Given this list of marker genes LRRC23, MARK4, HAP1, WDR11, CFAP119, TESK1, CFAP74, AHI1, MCRS1, CEP250, PRICKLE1 (prickle planar cell polarity protein 1), CEP78, CFAP263, CFAP57, MICALL1, CFAP97D1, TAPT1, SSNA1, CC2D2B, PPP1R35, PKHD1, DNALI1, KLC3, CYLD, TMEM237, B3GLCT, GSN, SEPTIN7 (septin 7), CCDC65, TBC1D2B, E2F4, DYNC2I1, TMEM80, CEP19 (NCBI Gene Id 84984), CPLANE1, DZIP1L, PLA2G3, RFX4, MNS1, KIF27, CEP89, POC1A, WDR44, CFAP221, CFAP410 (cilia and flagella associated protein 410), RSPH4A, CILK1 (ciliogenesis associated kinase 1), ONECUT1, CDC14C, LRRC61, FAM161A, GDI2, ODF2L, CFAP70, IFT52, CCNO, GMNC, RILPL1, TMEM138, FLNA, CFAP73, B9D1 (B9 domain containing 1), FNBP1L, CFAP20, CBY1, TEKT4, TBC1D3, WDR90, PCM1, HYLS1, ATXN10, RFX3, MAK, FBXW8, RABL2B, NEURL1, NEDD9, GFY, PLK4, CEP120, TBC1D7, TBC1D30 (NCBI Gene Id 23329), CCDC38, CFAP100 (NCBI Gene Id 348807, cilia and flagella associated protein 100), BBOF1, CCDC88A, RABEP2, CFAP44, DNAI3, DZIP1, TBC1D16, FSIP2, C2CD3, TRIM32 (NCBI Gene Id 3971), RP1L1, TBC1D21, SPACA9, CFAP46, ROPN1, FBF1, ARL3, CWH43, LUZP1 (NCBI Gene Id 7798), TCTN1, HOATZ, MAPRE1, EHD1, CIMAP3, CENPJ, CCDC13, NME8, PIERCE2, SGSM3, INTU (NCBI Gene Id 27152), SPEF2, DNAAF1, TCTN2, TBC1D15, TTLL8, KCNQ1, CEP20, WDR35, RP2, CCDC63, DYNLT2B, IFT56, DRC1, FOXJ1, CCDC40, CCDC159, DUSP23, SPEF1, ACTR3, PIERCE1, IFT88, LRRC46, IQUB, SPAG6, DNAI1, DNAH7, ADAMTS16, RAB3IP, RFX2, TBC1D14, DNAAF3, LIMK2, TBC1D10B, DNAH17, MAP4, BBS2, KIFAP3, TMEM231, BBS10, ATG5, AKT1, GBF1, KIF24, BBS1, IFT70B, DNHD1, ATP6V1D, DISC1, ATAT1, ALPK1, BBS5, RAB8A, CEP131, ODF2, DCTN1, ABLIM3, DYNLL1, FUZ, IFT43, BBS7, ROPN1B, KIF19, IFT27, EXOC5, CCDC88C, MARCHF7 (NCBI Gene Id 64844), UNC119B, DAW1, CFAP54, CEP97, STK36, LCA5, ATMIN, ARF4, TBC1D20, CFAP298 (cilia and flagella associated protein 298), EHD2, CFAP61, CEP70, LIMA1, CEP164, SCLT1, DYNC2I2, NUDCD3, JHY, POC1B, ELMOD3, CLXN, IFT70A, RSPH9, SAXO1, ENTR1 (NCBI Gene Id 10807), CFAP47 (cilia and flagella associated protein 47), NPHP3, CDKL5, ASAP1, RAB23, SPAG16, FHDC1, TTC29, DNAH1, EHD3, IFT172, YIF1B, ONECUT2, RSPH1, CFAP53, UBE2B, WDPCP, RO60, ZMYND12, DRC7, CCDC39, TPGS1, PFN4, WWTR1, ENKD1, CPLANE2, CFAP126, EVI5L, SSX2IP, PCNT, IFT57, CEP162, IFT25, TTC21B, MKS1, RILP, TBC1D10C, PARVA, CCDC15, CC2D2A, MACIR, KIF3B, TUB, DNMBP, TEKT3, CIBAR2, NEK1 (NCBI Gene Id 51037), CCDC103, DNAAF6, IFT20, DNAI2, CCDC42, KCNJ10, TBC1D31, CDC14A, ABCC4, WRAP73, CCP110, IFT81, SPAG1, TBC1D24, FAM149B1, TEKT1, TBC1D22B, CFAP91, RAB1A, TBC1D1, KIAA0753, CCDC57, BBS12, DNAH5, CDK10, GAS8, IFT140, DNAAF4, RTTN, AURKA, ACTR2, GORAB, TCHP, DYNC2LI1, ARL13B, LCA5L, DMD, FBXO24, KIAA0586, TCTN3, CFAP65, CFAP161, CEP290, TMEM67, OCRL, TBC1D17, DNAJB13, KCTD17, USP6NL, RAB11A, PIBF1, TTC12, GSK3B, FAM161B, NME5, TXNDC15, RPGRIP1L, MEIG1, TTLL1, TTC21A, DNAH2, USP9X, ARMC2, CFAP184, TBC1D32, LPAR1, SYNE2 (spectrin repeat containing nuclear envelope protein 2), IFT22, B9D2, ODAD1, RP1, SEPTIN9, TTC17, EHD4, IQCB1, TMEM216 (transmembrane protein 216), CFAP206, CCDC32, ERICH3, DNAAF10, DNAI4, TMEM107, IFT74, CSNK1D, TBC1D19 (NCBI Gene Id 55296), RAB11FIP3, ODAD2, PKD2, HTT, ZMYND10, CEP135, RAB34, TTLL3, RILPL2, ARL6, VANGL2, ARHGAP35, CNTROB, BLOC1S6 (NCBI Gene Id 26258), IFT80, PTPN23, GALNT11, BBS4, CELSR2, TTC8, NOTO, DNAAF11, CROCC, CFAP58, DTNBP1, CEP350 (centrosomal protein 350), IQCG, ARL13A, MAPK15, TBC1D13, DCX, IFT46, CATIP, CFAP43, CIBAR1, YAP1, CEP83, OFD1, TBC1D5, DCDC2, SPAG17, TMEM17, RABGAP1, TBC1D9B, NDUFAF2, BBIP1, RRP7A, TRAF3IP1, TBC1D8, CFAP157, CFAP69, GK2, WDR19, TOGARAM1, TSGA10IP, TBC1D22A (NCBI Gene Id 25771), TEKT5, ODAD4, CDC14B, HYDIN, INPP5E, CEP41, BBS9, DYNC2H1, NME7, ELMOD1, CEP126, DNAL1, SDCCAG8, DNAAF2, TTC39C, UBXN10, CDKL1, ARMC9, CLUAP1, NECTIN2, CEP128, TTLL5, SEPTIN2, KIF3A, AVIL, NHERF1, RPGRIP1, KCNF1, EVI5, TTBK2, DNAAF8, CCDC146, LAMA5, SNX10, ARMC12, MPHOSPH9, HDAC6, ATG3, SNAP29, NOTCH1, SPATA6, RAB8B, MKKS, ABLIM1, AKAP4, IFT122, TBC1D10A (TBC1 domain family member 10A), RSPH6A, ODAD3, PDCL2, ATP6V0D1, TEKT2, RAB17, VDAC3, RPGR, TBC1D2, CCDC28B, PTPDC1, MCIDAS, DNAH8, DNAAF5, TRAPPC14, CLCN4, LRGUK, CCDC66 (NCBI Gene Id 285331), here is a description of the gene set: Human Gene Set: GOBP_CILIUM_ORGANIZATION studied in species Homo sapiens A process that is carried out at the cellular level which results in the assembly, arrangement of constituent parts, or disassembly of a cilium, a specialized eukaryotic organelle that consists of a filiform extrusion of the cell surface. Each cilium is bounded by an extrusion of the cytoplasmic membrane, and contains a regular longitudinal array of microtubules, anchored basally in a centriole.